The following is a description of a gene set: from publication Chen Y, Wang X (PMID 31504780) studied in species Mus musculus Mouse Gene Set: MIR_1934_5P Genes predicted to be targets of miRBase v22 microRNA mmu_miR_1934_5p in miRDB v6.0 with MirTarget v4 prediction scores > 80 (high confidence targets)., and this is the list of marker genes: Pcdha7, Maco1 (macoilin 1), Pcdha5, Pcdha12, Amer3, Nlrp1a, 6430571L13Rik, Dcx, Mrpl51, Unc5c (NCBI Gene Id 99539), Dlg5, Spink5, Ppargc1a, Mall, Calcoco2, Stk3, Garin5a (golgi associated RAB2 interactor 5A), Cacna1e, Creb1, Med13l (mediator complex subunit 13-like), Pcdha11, Zfp335, Trim2, Crtc1, Lrrc75a, Mgl2, Pcdha6, Azin1, Upk3a, Htra3, Vapa, Slc23a2, Ddx41, Plch1, Inpp5f, Frmd5, Gdap2, Brd10, Pcdha1, She, Atosa, Cd101, Fbxl20, Pcdha4, Ntn1, Cyp3a13, Dpp4, Pum2, Pcdha10, Pwwp3b, Hif1a, Poglut1, Eif4g3, Map4k2, Pcdhac1, Carf, Flot2, Ccl19, Cpne6, Dlx3, Tead1, B9d1, Sfxn2, Cx3cr1, Pcdha9, Adgrl4, Gys1, Tmem184b, Mfsd4b2, Patz1, Acsl1, Ubiad1, Dcp2, Vnn1, Gale, Klhl31, Sufu, Rbm20, Rad9a, Gfra2, Idh3b, Gss, Gigyf2, Nherf1, Rasgrp1, Nom1, Rragd, Yipf5, Phldb1 (pleckstrin homology like domain, family B, member 1), Pcdha3, Ptbp2, Pcdha2, Arhgef2, Tpm2, Cphx1, Pcdhac2, Jakmip3